Given this list of marker genes B2m, Stat5a, Ltv1, Timm10, Ptp4a2, Fas, Senp1, Eif4g1, Sdc4, Batf, Psmb10, Ly6e, Fbl, Nfkb1, Psme1 (proteasome (prosome, macropain) activator subunit 1 (PA28 alpha)), Sting1, Ppia, G3bp1, Cep162, Uqcc2, Sec11c (NCBI Gene Id 66286), Kif3b, Icam1, Tnip1, Gbp4, Creb1, Tesc, Gbp3, Tubb5, Prmt1, Pa2g4, Abcc1, Fchsd2, Mif, Kmt2a, Fam136a, Slc14a1, Ppa1, Ikbke, Tuba1b, Cdk4, Lyar, Phb1, Nfkb2 (NCBI Gene Id 18034), Calhm6, Cd226, Ccdc88b, Tpm3, Hopx, Timm13, Dtx3l, Aebp2, Ncl, Npm3, Serpina3g, Cct5, Ltb, Cops5, Ranbp1, Ubxn2a, Apobec3, Psme2, Sacs, C1qbp, Elp5, Cmtm7, Cxcl10 (NCBI Gene Id 15945), Psma5, Tmsb10, Tox4, Il2rg, Traf1, Edf1, Pim1, Fkbp2, Pfn1, Psmb3 (NCBI Gene Id 99155), Lcp1, Cyba, Lta, Dcaf15, Cd83, Cers2, Erh, Birc3, Plagl2 (pleiomorphic adenoma gene-like 2), Nfkbie, Mrpl17, Lpcat1, Med11, Psmb8, Tmem158, H2az1, Tomm40, Calr, Kdm2b, Apex1, Usp25, Parp14, Cish, Sp110, Marcksl1, Irf2bp2, Prpf19, Arpp19, Gprin3, Nfkbia, Sumo2 (NCBI Gene Id 235709), Ier5, Zmiz2, Ncoa7, Cd82, Hsp90ab1, Gadd45b, Akr1b1, Pitrm1, Myo1g, H2-K1, Jade2, Ifi47, Nhp2, Lsm7, Emc4, Tnfrsf4, Ccr6, Tapbpl, Bcl2l1, Ncf4, Mettl1, Rbm42, Sdhaf1 (succinate dehydrogenase complex assembly factor 1), Tap1, Ptma, Slfn2, Pglyrp2, Stat1, Larp1, Eif5a, Ppp1r14b, Cdc37, Phgdh, Asxl1 (NCBI Gene Id 228790), Snx1, Gbp2, Atp9b, Tapbp, Tcf7, Vars1, Relb, Mndal, Tank, Ccnd2, Ddx21, B4galt1, Bcl3, Rsl24d1, Grap, here is a description of the gene set: from publication Cui A, Huang T, Li S, Ma A, Pérez JL, Sander C, Keskin DB, Wu CJ, Fraenkel E, Hacohen N (PMID 38057668) Mouse Gene Set: CUI_TREG_TL1A_RESPONSE_UP Genes positively differentially expressed in cell type: Treg upon treatment with cytokine: TL1A in mouse lymph nodes in vivo. Cytokines mediate cell-cell communication in the immune system and represent important therapeutic targets. A myriad of studies have highlighted their central role in immune function, yet we lack a global view of the cellular responses of each immune cell type to each cytokine. To address this gap, the authors created the Immune Dictionary, a compendium of single-cell transcriptomic profiles of more than 17 immune cell types in response to each of 86 cytokines (>1,400 cytokine-cell type combinations) in mouse lymph nodes in vivo. A cytokine-centric view of the dictionary revealed that most cytokines induce highly cell-type-specific responses. For example, the inflammatory cytokine interleukin-1β induces distinct gene programmes in almost every cell type. A cell-type-centric view of the dictionary identified more than 66 cytokine-driven cellular polarization states across immune cell types, including previously uncharacterized states such as an interleukin-18-induced polyfunctional natural killer cell state. species: Mus musculus